Given this list of marker genes PIK3R6, ARHGEF6 (Rac/Cdc42 guanine nucleotide exchange factor 6), GNB4, GNG4 (G protein subunit gamma 4), PLCB1, RHOA, AKT1, PDPK1, PAK1, GNG10, GNG8, GNGT1, CDC42, GNG5, AKT3, GNGT2, GNB1, GNG12, GNG7, GNG2, GNG13, GNB2, AKT2, PLCB2, PLCB3, PIK3CG, BTK, PIK3R5, GNB3, GNB5, GNG3, GNG11, here is a description of the gene set: G-protein beta:gamma signalling species: Homo sapiens Human Gene Set: REACTOME_G_PROTEIN_BETA_GAMMA_SIGNALLING